Given this list of marker genes Slc17a7, Nfib, Cacng7, Lrrc4b, Dab2ip, Dlg4, Syde1, Bin1, Cacng2, here is a description of the gene set: An axon arising from cerebellar projecting cells in the cochlea, vestibular nuclei, spinal cord, reticular formation, cerebellar nuclei and basilar pontine nuclei. Mossy fibers enter through all three cerebellar peduncles and send collaterals to the deep cerebellar nuclei, then branch in the white matter and terminate in the granule cell layer. Through this branching, a given mossy fiber can innervate several folia. Mossy fibers synapse on granule cells. The synaptic contacts are made at enlargements along the length of the mossy fiber called mossy fiber rosettes. The enlargements of the rosettes give the axons a mossy-looking appearance in Golgi stained preparations. species: Mus musculus Mouse Gene Set: GOCC_CEREBELLAR_MOSSY_FIBER